Given this list of marker genes COMT, ADORA3, ADRA2A, ADRA2B, ADORA2A, OXT, GHSR, KCNB1, FFAR3, STX1A, CRH, ADRA2C, P2RY1, here is a description of the gene set: species: Homo sapiens Human Gene Set: GOBP_NOREPINEPHRINE_SECRETION The regulated release of norepinephrine by a cell. Norepinephrine is a catecholamine and it acts as a hormone and as a neurotransmitter of most of the sympathetic nervous system.